The following is a description of a gene set: studied in species Mus musculus Toll-like receptors (TLRs) induce a multi-component inflammatory response that must be tightly regulated to avoid tissue damage. Most known regulatory mechanisms target TLR signalling pathways and thus broadly inhibit multiple aspects of the inflammatory response. Given the functional diversity of TLR-induced genes, we proposed that additional, gene-specific regulatory mechanisms exist to allow individual aspects of the TLR-induced response to be differentially regulated. Using an in vitro system of lipopolysaccharide tolerance in murine macrophages, we show that TLR-induced genes fall into two categories on the basis of their functions and regulatory requirements. We demonstrate that representatives from the two classes acquire distinct patterns of TLR-induced chromatin modifications. These gene-specific chromatin modifications are associated with transient silencing of one class of genes, which includes pro-inflammatory mediators, and priming of the second class, which includes antimicrobial effectors. These findings illustrate an adaptive response in macrophages and reveal component-specific regulation of inflammation. from publication Foster SL, Hargreaves DC, Medzhitov R (PMID 17538624) Mouse Gene Set: FOSTER_TOLERANT_MACROPHAGE_UP Class T (tolerizeable) genes: induced during the first LPS stimulation and either not re-induced or induced to a much lesser degree in tolerant macrophages., and this is the list of marker genes: Slc16a3, 4933430I17Rik, Nupr1, Treml2, Pitx1, Oas3, Il1rn, Bak1, Aoah, Rasgrp1, Zdhhc18, Rtn4r, Gem, H2-Q5, Arhgap8, Lox, ENSMUSG00000121828, Sell, Hp, Thbs1, Elk3, Ifrd1, Dnajc1, Brdt, Cfb, Ms4a4c, Adhfe1, Clmp, Ms4a6d, Selenow, Bst1, H2-T10, Adora2a, Rbpms, 1700113A16Rik, Il18bp, Smg1, Tmem178, Cdc42ep2 (NCBI Gene Id 68573), Zfp811, Mchr1, U90926, Slc7a11, Id2, Tgfbi, Etf1, Lmo4 (NCBI Gene Id 16911), 2510009E07Rik, Trim23, Riok3, ENSMUSG00000130773, Lcn2, Glrx, Ankrd66, Smad6, Ppp3cc, Sgk1, Cln5, Nav2 (neuron navigator 2), Peds1 (plasmanylethanolamine desaturase 1), Rnf149, Met (NCBI Gene Id 194383), Slfn4, Rgl1, Traf3, Tank, Cxadr, Lrrc4, Cep85l, Slamf9, Rab10, Fpr2, Ppfia3, Slc31a1, Gsta3, Acsl1, Ptges, Marco, Fabp7 (NCBI Gene Id 12140), Naip1, Itgal, Wnk2, Prkrip1, Galnt15, Btg3, Slfn3, Smad7, Pvr, Igsf6, Zdhhc2, Ccl8, Slc31a2, Orai2, Rnaset2b, Rab20, Marchf5, A330040F15Rik, Ifi44, Txnrd1, Jag1, Rgs1, Slx4ip, Cp, Slc25a37, Iqsec2, H2-Q4 (histocompatibility 2, Q region locus 4), H2-Q10, Gpr18, Nrip2, Mcoln2, Stat1, Trem3, Ly6a, Tcstv3, Fgl2, Ppm1h, Ms4a6c, Ift57, Irf7, Gosr1, Fpr1, Lrrc8c, Pgap2, Rho, Syk, Morrbid, Zc3h12c, Gpr33 (G protein-coupled receptor 33), Xaf1, Cxcl9, Clec4e, Plpp1, Mthfd2, Fbrsl1, Ass1, Cfap210, Spic, Tnfrsf1b, Ccdc68, Kpna4, Atxn7l1, Isg20, Plpp3, Tspo, Csprs, Klra2, Ly6i, Cd38, Fabp3-ps1, Phlpp1, Bst2, Spata31f1a, Ccdc71l, Cst7, Psmd10, Gpr61, Hilpda, Vmn1r40 (NCBI Gene Id 113855), Cd200, Mtdh, Cttn, Mreg, Smurf1, Serpinb9, Slc7a8, Irak3, H2-Q6, Tent5c, Rab32, Saa3, F10 (NCBI Gene Id 14058), Id3, Cycs, Slc7a2 (solute carrier family 7 (cationic amino acid transporter, y+ system), member 2), Tmcc3, Agtrap, Orm1, Ell2, H2-T24, Msr1, H2-T23 (histocompatibility 2, T region locus 23), Slfn1, Zfand3, Ighg1, Pik3ap1, Prdx5, Dcbld2, Slc13a3